Given this list of marker genes RNASEH2A, POLR3K, EED, SLC7A5, PSMD1, H2AZ1, TYMS, CALML4, GPI, NDUFA4, PSMD3, UTP11, LMAN1, NOL12, PHLDA2, TRIM58, E2F6, HPGD, CTNNA1, NSMCE4A, MRPL40, MYH10, AKR1B1, ZBED2, POLB, PSMD13, ASIC3, LTBR, C3orf52, PEX3, MID1IP1, DCAF7, TFDP1, KIF23, CDC27, BTBD3, C9orf40, POLR2F, SLC39A8, NFKBIE, PPP1R2, STK3, CSNK2B, TBL3, PLSCR1, METTL13, ORC6, JPT1, NFIC, TPX2, RRM1, SPAG5, MAPKAPK3, FBXO5, SDC4, FLOT1, FAH, EHD4, MCM5, PA2G4, TIPIN, CKS1B, GGH, CLNS1A, ENPP2, EIF4A3, HBEGF, APIP, PTEN, RAB11FIP1, TRAPPC3, KIFBP, ALG5, GPN3, DIXDC1, ATP5MC1, EXOSC9, NTHL1 (NCBI Gene Id 4913), PFDN4, PSMD6, CKS2, MARCHF5, ACACA, TAP1, TRIM26, CSF2, CREM, GUCY1B1, CCR1, PHGDH, MTCH2 (NCBI Gene Id 23788), OAS3 (2'-5'-oligoadenylate synthetase 3), MRPL12 (mitochondrial ribosomal protein L12), CD8B, NAA35, RRP7A, QPRT, BMP2K, C21orf91, MYH6, ARF3, PRMT5, NME7, PDSS1, LRRN3, PSMB5, BLM, IL2RA, CEBPA, SLC39A9, RPS27L, NDUFAF1 (NADH:ubiquinone oxidoreductase complex assembly factor 1), KDELR2, IDH3A, PRR11, GLRX2, CDC25C, NUSAP1, SCN3A, PAICS, EIF5B, TUBB, CEBPG, TIMELESS, TOR3A, MCTP2, FN1, NDUFV2, H1-0, PYCR1, CENPA, CSE1L, INVS, NSFL1C, HNRNPM, SPP1, CHST11, PTBP3, SDHB, PDK3, STEAP1, NGDN, LAG3, LSM4, FES, TUBB3, GLA, SERPINB1, SLA (NCBI Gene Id 6503), SMS, ASNSD1, SUOX, NDUFA6, CYC1, SLCO4A1, TNF, FAM200C, ETFA, EMC1, MYG1, SDHC, H2BC11, PMAIP1, BRCA1, PCTP, OXCT1, TRIM21, NDUFS1, UBE2I, APOD, PCNX4, MFAP1, TIGAR, SMCO4, MKLN1, PIK3C3, BAG2, PSENEN, PINLYP, HSD17B12, EPAS1, PRMT7, TUBB6 (NCBI Gene Id 84617), EIF3I, IL10, KIF4A, EFCAB11, PRDX3, STIL, TWSG1, CERS4, NCAPG2, CD200, SCCPDH, GLUD1, DSG2, CDCA4, COQ2, RRM2, here is a description of the gene set: from publication Jeffrey KL, Brummer T, Rolph MS, Liu SM, Callejas NA, Grumont RJ, Gillieron C, Mackay F, Grey S, Camps M, Rommel C, Gerondakis SD, Mackay CR (PMID 16474395) In the present study we used Affymetrix oligonucleotide microarrays to produce gene transcription profiles for the major leukocyte types in humans. This comprehensive dataset enabled us to not only establish which genes were expressed in each leukocyte type, but also which genes were expressed in each subset after activation. The used of a comprehensive dataset of gene profiles from all the major human leukocyte subsets enabled a novel and powerful means for identification of genes associated with single leukocyte subsets, or different immune paradigms. Genes down-regulated in comparison of effective memory CD4 T cells versus Th1 cells. Human Gene Set: GSE3982_EFF_MEMORY_CD4_TCELL_VS_TH1_DN studied in species Homo sapiens